The following is a description of a gene set: studied in species Mus musculus from publication Cui A, Huang T, Li S, Ma A, Pérez JL, Sander C, Keskin DB, Wu CJ, Fraenkel E, Hacohen N (PMID 38057668) Cytokines mediate cell-cell communication in the immune system and represent important therapeutic targets. A myriad of studies have highlighted their central role in immune function, yet we lack a global view of the cellular responses of each immune cell type to each cytokine. To address this gap, the authors created the Immune Dictionary, a compendium of single-cell transcriptomic profiles of more than 17 immune cell types in response to each of 86 cytokines (>1,400 cytokine-cell type combinations) in mouse lymph nodes in vivo. A cytokine-centric view of the dictionary revealed that most cytokines induce highly cell-type-specific responses. For example, the inflammatory cytokine interleukin-1β induces distinct gene programmes in almost every cell type. A cell-type-centric view of the dictionary identified more than 66 cytokine-driven cellular polarization states across immune cell types, including previously uncharacterized states such as an interleukin-18-induced polyfunctional natural killer cell state. Mouse Gene Set: CUI_LANGERHANS_IFNG_RESPONSE_DN Genes negatively differentially expressed in cell type: Langerhans upon treatment with cytokine: IFN-γ in mouse lymph nodes in vivo., and this is the list of marker genes: Ankrd33b, Hspa1a, Kctd12, Arl5c, Hspa1b